The following is a description of a gene set: Human Gene Set: HP_TRUNCUS_ARTERIOSUS Truncus arteriosus species: Homo sapiens A single arterial trunk arises from the cardiac mass. The pulmonary arteries, aorta and coronary arteries arise from this single trunk with no evidence of another outflow tract., and this is the list of marker genes: PLXND1, PUF60, NEK8, GJA8, ARVCF, ITPR1, RAB34, TBX1, SEC24C, UFD1, PSMD12, HIRA, NKX2-5, RREB1, STRA6, GP1BB, CRKL, COMT, SMAD2, NKX2-6, MAPK1, GATA6, TMEM260, BCR, JMJD1C, GJA5, DLL4